Given this list of marker genes VPS51, TTC22, LRCH3, SYNE1, SMIM14, C16orf54, ZNF318, RPS29, PLCB2, TP53INP1, TCP11L2, RNF38, MBNL3, KLRG1, MCHR2, HHAT, VMAC, SLC25A45, PCYOX1L, BTN3A3, VAC14 (NCBI Gene Id 55697), CRBN, ATP6V0D1, PLAAT4, PRDM2, OLFM2, FHIP1B, CEACAM6, SGSM2, SIRPG, FCMR, ATG2B, PYHIN1, MAN1B1, ASAP1, EEIG1, GPR18, CTDSP2, LINC00467, C5, NADSYN1, CYB561A3, ZNF76, EHD1, DCTN1, HS1BP3, TRAM2 (NCBI Gene Id 9697), CRADD (CASP2 and RIPK1 domain containing adaptor with death domain), PATL2 (PAT1 homolog 2), XYLB, AGAP1, GPR183, FAM120C, SCARB2, VSIG1, EVI2B, CEACAM21, TBCEL, MAPK1, MFSD3, SLAMF6, GLMP, CHST7, UBA7 (NCBI Gene Id 7875), ARHGEF9, EEF2, COMMD9, CDC42EP3, ARSA, DLGAP1-AS1, TTYH2, JMY, PCED1A, HERPUD2, GVINP1, PREX1, ARHGAP12, CYB5D2, KLF12, S100A4, AKAP13, CLIC5, ZMAT1, LPXN, SNX20, TP53TG1, KCNA2, CDNF, ZAP70, AP5Z1, TET1, EXOC4, FYB1, MYLK4, CHIC2, SLC9A9, SMIM19, TMEM63A, LY9, CNOT6L, TEPSIN, ZER1, LINC01783, SLC35D2, ICAM2, SUMF1, MAP3K7CL, RPRD2, TRIM8, RGS14, TSC22D1, C12orf42, DPEP2, DYRK1B, ARMC2, ANK1, WWC3 (NCBI Gene Id 55841), DUSP16 (dual specificity phosphatase 16), MFGE8, APBB1, PINK1, NUDT7, PNRC1, RPL18, ZNF280D, APBB1IP, SLC12A9, USP20, ABCC10, ABAT, LINC00649, ANO9, UROS, RPL34, HIVEP2, BTBD2, HPS1, DCP1B, EVL, SMPD1, LIME1, ITM2B, LEPROTL1, TMEM150A, RPS27, RASGEF1A, HRH4, YPEL3, SYNE2, TRANK1, PLA2G6, DOCK9, PARP3, CTSA, LAMP1, NIPAL2, TPST2, TMBIM1, DHRS12, CTSF, NADK, TPP1, PBXIP1, LINC00910, IKZF3, GBA1, RPS18, CD84, SCARNA7, ZBTB44, TENM1, ABCD4 (ATP binding cassette subfamily D member 4), CD44, MSC, ARHGAP45, NFIA, JAK1, SLC39A13 (NCBI Gene Id 91252), TMC6, PIGQ, ADA2, TGFBR3, ZMYM4, CYP4V2, SLC66A3, VAMP5, MXD4, RUNX2, CD52, TIGIT, TBCK, COMMD6, CASP4, RCSD1, WDR81, ROBO1, SLC46A3, COLQ, MAN1A2, CD6, here is a description of the gene set: Human Gene Set: GSE32986_UNSTIM_VS_CURDLAN_HIGHDOSE_STIM_DC_DN A simultaneous engagement of different pathogen recognition receptors provides a tailor made adaptive immunity for an efficient defence against distinct pathogens. For example, cross talk of TLR and c-type lectin signalling effectively shapes distinct gene expression patterns by integrating the signals at the level of NF-κB. Here, we extend this principle to a strong synergism between the Dectin-1 agonist, curdlan, and an inflammatory growth factor, GM-CSF. Both together act in synergy in inducing a strong inflammatory signature which converts immature DCs to potent effector DCs. A variety of cytokines (IL-1β, IL-6, TNF-α, IL-2 and IL-12p70), costimulatory molecules (CD80, CD86, CD40 and CD70), chemokines (CxCl1, CxCl2, CxCl3, CCl12, CCl17) as well as receptors and molecules involved in fugal recognition and immunity such as Mincle, Dectin-1, Dectin-2 and Pentraxin 3 are strongly up-regulated in DC treated simultaneously with curdlan and GM-CSF. The synergistic effect of both stimuli resulted in strong IKBα phosphorylation, in its rapid degradation and in enhanced nuclear translocation of all NF-κB subunits. We further identified MAPK ERK, as one possible integration site of both signals, since its phosphorylation was clearly augmented when curdlan was co-applied with GM-CSF. Our data demonstrate that the immunomodulatory activity of curdlan requires an additional signal provided by GM-CSF to successfully initiate a robust β-glucan specific cytokine and chemokine response. The integration of both signals clearly prime and tailor a more effective innate and adaptive response against invading microbes and fungi. from publication Min L, Isa SA, Fam WN, Sze SK, Beretta O, Mortellaro A, Ruedl C (PMID 22250091) species: Homo sapiens Genes down-regulated in bone marrow-derived dendritic cells: unstimulated versus high dose of 1,3-beta-D-oligoglucan.